The following is a description of a gene set: species: Homo sapiens Human Gene Set: GOCC_ENDOLYSOSOME_LUMEN The volume enclosed by the membrane of an endolysosome. An endolysosome is a transient hybrid organelle formed by fusion of a late endosome with a lysosome., and this is the list of marker genes: LGMN, CTSS, CTSL, CTSK (NCBI Gene Id 1513), CTSB